Given this list of marker genes ABCB1, LRP5, NDP, MFSD2A, CLDN5, CTNNB1, here is a description of the gene set: studied in species Homo sapiens Establishment of the barrier between the blood and the retina. The blood-retinal barrier is located at two levels, forming an outer barrier in the retinal pigment epithelium and an inner barrier in the endothelial membrane of the retinal vessels. Both these membranes have tight junctions of the 'nonleaky' type. Human Gene Set: GOBP_ESTABLISHMENT_OF_BLOOD_RETINAL_BARRIER